Given this list of marker genes ALAD, MOG, GLUD1, ADORA2A, SLC25A15, IFT56 (intraflagellar transport 56), TRAF7 (NCBI Gene Id 84231), PWRN1, AGRN, ETFA, CTSH, POLR3K (NCBI Gene Id 51728), LNPK, ASS1, NOTCH3, NDUFA2, PEX2, MUSK, MT-CO2, GBA1, SLC2A3, CTNNB1, SQOR, ZNF365, ATP1A3 (NCBI Gene Id 95633), DHCR7, PRF1, HADHB, DUOX2, SPP1, TBC1D24, PLP1, SLC19A3, P2RY11, CDKN2B (cyclin dependent kinase inhibitor 2B), PTS, HADH, CYC1, ACADM, ATP1A2, SCN4A, HMBS, MRAP, SAT1, SNCB, HNF1A, MT-ND5, PRRT2, NDUFS4, MMAA, HLA-DQB1, UPB1, CASR, CNBP, PLA2G6, MT-TL1, CHRND, PSAP, CPS1, HADHA, STAT4, KCNJ11, MT-CO1, MYD88, PIGG, MT-TF, NOTCH2NLC, CLCNKB, TANGO2, STAT3, SCN1A, APP, TWNK, MT-TW, IL12B, GPR101, TXNRD2, NNT, BCKDHA, CPT1A, STX11, PDHA1, OTC, MAN2B1, SLC22A5, NFKB2, LRP4, DMPK, POU2AF1, PPOX, SOX10, HERC2, GLYCTK (glycerate kinase), MEN1, TBK1, SLC26A4, SMARCE1, ACAT1, PCCA (NCBI Gene Id 5095), NDUFS8, KYNU, TNPO3, MT-CYB, MT-TS2, MAGEL2, PTRHD1, CACNA1A, NPAP1, NF2, SLC12A3, MYOD1, PCCB, MKRN3, SNCA, NHLRC1, NAB2, YY1, HCRT, SPR, NAGS, IVD, HMGCL, GCK, SHQ1, KCNQ1, TRAF3, UCP2, LYRM7 (NCBI Gene Id 90624), ARSA, UBAP2L (NCBI Gene Id 9898), SPIB, PRR12, TERT, DPYS, HEXB, TRANK1, IL18BP, RNU4ATAC, ZNHIT3, FKTN, FBP1, NAXE (NCBI Gene Id 128240), CFHR3, MT-CO3, HNF4A, DNMT1, FOXE1, CDKN2C, INS, MT-TQ, NAA10, AUH, IL12A, CDKN1A, TICAM1, SMARCB1 (SWI/SNF related, matrix associated, actin dependent regulator of chromatin, subfamily b, member 1), GK, SNORD116-1, EPM2A, CHRNB1, PIK3CA, INSR, ISCA2, CDKN1B, GFAP, AKT2, MMUT, SLC13A3, PWAR1, IRF5, TNFSF15, COL3A1, LARGE1, MT-ND6, TDP2, MC2R, GCSH, MCCC1, STXBP2, UNC93B1, TTC19, CPT2, HMGCS2 (NCBI Gene Id 3158), BRAF, AK9, FKRP, PRPS1, ASL, CFHR1, MT-ND4 (mitochondrially encoded NADH:ubiquinone oxidoreductase core subunit 4), MMEL1, CHRNA1, IL12RB1, SLC25A13, MCCC2, HLCS, ALDOB, EIF2B5, SNORD115-1, GNA11, PAX8, HLA-DRB1, GCDH, MTRR, AIP, STAR, SLC7A7 (solute carrier family 7 member 7), HTT, ABCD1, MT-ND1, CFH, TUBA1A, COL13A1, SLC25A20, MMAB, AKT1, RAPSN (NCBI Gene Id 85713), NKX2-5, HLA-B, RANBP2, ETFB, NKX2-1, ASH1L, AARS1, SUFU, GJB1, THRA, SMO, TSHR, POMT2, ABCC8, PRNP, CHRNE, IRAK1, ETFDH, SLC18A3, LONP1 (NCBI Gene Id 9361), DOK7, POMT1, ATP7B, NUP88, KIF21A, MT-TH, PDX1, BAP1, STAT6 (signal transducer and activator of transcription 6, NCBI Gene Id 6778), KCNE1, TNFSF4, COA8 (cytochrome c oxidase assembly factor 8), PDGFB, TLR3, MLX, POLG, UNC13D, here is a description of the gene set: studied in species Homo sapiens Human Gene Set: HP_REDUCED_CONSCIOUSNESS Abnormally diminished level of attention, responsiveness, or wakefulness. Reduced consciousness